The following is a description of a gene set: Mouse Gene Set: MARTIN_NFKB_TARGETS_DN species: Mus musculus NF-kB-controlled genes down-regulated in endothelial cells in response to viral GPCR protein. from publication Martin D, Galisteo R, Ji Y, Montaner S, Gutkind JS (PMID 17934524) Kaposi's sarcoma (KS) is the most frequent AIDS-associated malignancy, etiologically linked to the infection with the human herpesvirus 8 (HHV-8/KSHV). This member of the gamma-herpesviridae family encodes 81 open reading frames, several bearing oncogenic potential. A constitutively active virally encoded G protein-coupled receptor (vGPCR) readily induces KS-like lesions when expressed in endothelial cells in vivo, and unmasks the oncogenic potential of other HHV-genes in a paracrine fashion. How vGPCR causes endothelial cell transformation is still not fully understood. Using full-genome microarray analysis we show here that the expression of nuclear factor-kappaB (NF-kappaB)-regulated genes is a prominent feature triggered by vGPCR in cells expressing this viral oncogene and in cells exposed to vGPCR-induced secretions, thus mimicking its paracrine effect. Indeed, vGPCR activates the NF-kappaB pathway potently, and NF-kappaB activation is a hallmark of both human and experimental KS. Of interest, whereas constitutive NF-kappaB signaling is not sufficient to promote endothelial cells transformation, NF-kappaB function is strictly required for vGPCR-induced direct and paracrine neoplasia. Taken together, these results strongly support the role of NF-kappaB regulated genes in KS pathogenesis, thus providing the rationale for the development of novel mechanism-based therapies for this angioproliferative disease., and this is the list of marker genes: Colgalt2, Ubn1, Brd1, Meak7, Zcwpw2, Slc14a2, Dhcr24, Dnase2a, Dgkq, Brsk1, Efnb3